Given this list of marker genes UBE2A, TFAP2A, KMT2A, MADD (NCBI Gene Id 8567), CHST3, VPS33A, CDK13, KDM6A, GDF3, CREBBP, RRAS, MAP2K2, WASHC5, CTCF, MAPK1, BSCL2, IRX5, RASA2, INTU, SPRED2, ACTG1, HUWE1, PIGG, PPP1CB, CNOT3, AEBP1 (AE binding protein 1), MAFB, RPS28, WBP11, SOS1, HDAC8, RRAS2, HNF1B, ZFX, MEOX1, RAB3GAP1, FGFRL1, ALG9, CAV1, TBX15, NANS, ALG12, ASCC3, CCDC22, PPARG, RAD21, ZNF699, MYH3, IGF1, MYO18B, LETM1, SCNM1, SRCAP, MBD5, H3-3A, MRAS, CPLX1, NELFA, CHN1, SLC25A24, KDM4B, AGPAT2, EFNB1, PTPN11, RAB3GAP2, TAF6, GNE, CDH2, BRD4, PEPD, SOS2, EP300 (E1A binding protein p300), SHOC2, SMARCD1, APC, NF1, PIK3C2A, EDEM3, KMT2D, XYLT2, B3GAT3, LZTR1, RIT1, CTBP1, NFIX, SMC3, KRAS, GDF6, FOS, ACTB, RAF1, NOTCH3, BRAF, WNT4, CHRNG, PIK3CD, USB1, ANKRD11, NSD2, CBL, NIPBL, CAVIN1, SMC1A, MAP2K1, NAA80, PGAP1, KNSTRN (NCBI Gene Id 90417), SALL4, ALDOA, NRAS, SRY, VPS51, ARHGEF2, PHF8, SMARCA2, ABCC9, SPRED1 (sprouty related EVH1 domain containing 1), KCNJ8, TMCO1, here is a description of the gene set: An anomaly in the placement or shape of the hairline (trichion) on the back of the head (neck), that is, the border between skin on the back of the head that has head hair. species: Homo sapiens Human Gene Set: HP_ABNORMALITY_OF_THE_POSTERIOR_HAIRLINE Abnormality of the posterior hairline